The following is a description of a gene set: Human Gene Set: GOBP_REGULATION_OF_MULTICELLULAR_ORGANISMAL_DEVELOPMENT Any process that modulates the frequency, rate or extent of multicellular organismal development. studied in species Homo sapiens, and this is the list of marker genes: CLDN5, TMEM64, HMOX1, ACTN3, COL4A3, TTBK1, LIG4, MAFG, PTGIS, SPAAR (small regulatory polypeptide of amino acid response), TJP1, SAV1, SUV39H1, CD69, ADAM8, MAN2A1, F11R, PHLDA2, SMAD1, SART1, RNH1, RC3H2, AGER, TLE6, PIM1, MIR361, NOG, FBXW8 (F-box and WD repeat domain containing 8), MTMR2 (NCBI Gene Id 8898), BMPR1A, CRB2, CHADL, PITHD1, MIR217, ZNF365, MIR181B1, EFEMP1, APLNR, PTPN11, CSF3, CCBE1, FXR2, FSTL4, THBS1, CTLA4, GPNMB, WNT7A (NCBI Gene Id 7476), ADA, FXR1 (FMR1 autosomal homolog 1), LTF, TNFRSF1A, CCSAP, MT3, IL10, FBXO7, CAMP, DYNLT1, CYP27B1, PTN, MAP1B, BRAF, SS18L1, AKT3, TLR2, IL1RL2, GATA6, APPL2, OAS2, LILRB4, INHBA, PAX2, SFRP1 (NCBI Gene Id 6422), WT1, SPRED3, PLXNB2, NOS3 (nitric oxide synthase 3), H4C16, FANCA, FGF1, BRPF3, LAMA5, NTN1, TGM2, TOX, SPP1, ACACB, MYCN, MIR590, MIR1298, AHI1, TGFB2, LRRC4B, CCN2, NKAP, JAK3, TRAK1, SFRP2, TBX21, HOXA5, CLSTN2, TCTA, IFNL1, MIR137, FZD3, CCL3, MAFF, IL6, YWHAH, AMIGO3, ITGB1, CIB1 (NCBI Gene Id 10519), KLF4, TMEM176A, LEO1, MIR29B1, ASCL1, KAT2A, BTG1, PRMT5, MIR126, SLC9B2, CDK5, MEGF8, GAB1 (GRB2 associated binding protein 1), MYDGF, SLC12A2, FGF13, CX3CL1, OTP, PTEN, DISC1, PLA2G3, TDG, HSPG2, RCOR1, MIR1224, ADM2, NKX6-1, STAT5B, ZBTB1, EP300, RFLNA (refilin A), SOX4, RLN2, FLRT2, SNAI2, TGIF1, FN1, S1PR3, CXCL10, KLF7, GATA4, IL2, CTDSP1 (NCBI Gene Id 58190), ZDHHC21, HCLS1, OSR1, RHOB, SENP1, RNF6, DCC, KIFAP3, HK2, ADM, BRINP1, CTNNA1, RHEX, COL4A2, MIR29C, CUL7, TNFRSF21, XBP1, SIRT6, SLITRK3, IL1A, SHOX2, TP53 (NCBI Gene Id 7157), ITPKA, SMARCD3, ROCK2, SOX17, TNFSF4, PTCH1 (patched 1), BCL11A, MTURN, SIRT2, HES7, CHI3L1, PIK3CG, SERPINE2, ZEB1 (zinc finger E-box binding homeobox 1), RBM15, DCSTAMP, LPIN1, EIF2AK3 (NCBI Gene Id 9451), METTL3, LEF1, NTRK1, KRT84, IGF1, EDN1, MIR106B, TMEM176B, IAPP, PIK3R6, RIPK1 (receptor interacting serine/threonine kinase 1), NCMAP, SHH, CD28, WNT9A, ACIN1, PLCG1, SMO, DBN1 (NCBI Gene Id 1627), TSC22D1, HRG, CDH1, SLC7A5 (NCBI Gene Id 8140), CHODL, OVOL2, NRP1, LINGO4, CDC73, RARB, KRAS, PRL, APCS, FLT1, IL23R, FKBPL, MAPK14, CCL19, B4GALT5, MIR509-1, TSPO, WNT11, OPRM1, MIR505, NKX3-2, ZFPM2, GSX2, ELL3, H4C2, WASF3, HMGB2, BMP2K (NCBI Gene Id 55589), PTHLH, SOX6, SMARCE1, PKP1, SMAD4, IL1RAPL1, IL7R, NIPBL, CYP1B1, ACTL6B, LGALS1, MIR17HG, NRG1, LYN, EFNA5, SEMA6D, SLIT1, SCX, HOXA7, SYT4, PIK3CB, RPS6KA6, GABPA, DLX1, GHSR, KITLG, SLC46A2, MAP2K2, AQP1, RFX3, ARID2, SMAD3, BRPF1, PHOSPHO1, ATP2B4, TPPP (tubulin polymerization promoting protein), NDFIP1, FRZB, TRADD, MIR142 (microRNA 142), SFN, PROC, ZNF354C (NCBI Gene Id 30832), WNK1, IPO7, MIR424, CR1, MCRS1, PLCB1, UFL1, NPR1, ZBED2, ELAPOR2, BCL6, LRG1, ANAPC2, IL27, SPI1, RUFY3, OPTC, WARS2, MIR29A, HELT, INO80, PLXNB3, EPHB2, HSF1, TWIST1, MIR30A, DLL4, NTRK2, PCK1, CTSC, SGPP1, EPHA2, H4C9 (NCBI Gene Id 8294), NOTCH4, MIR222, MITF, TLR3, FOXJ2, CXCR4, NFKBID, PDCD6, MIR34C, THY1, ANKRD54, THPO, STAT1, STAB1, P2RX5, PSEN1, POU4F2, ODAPH, DAG1, HAX1, FERMT1, IL1RAP, RAB21, PPARG, FAM20C, BRD7, TNF, RAG2, TNFSF12, SIGLEC15, HNF4A, MAF, NEDD9, MIR34B (microRNA 34b), ATOH1, PLK2, NKX2-5, GRID2, TRPM4, AGO1, CYBB, NGFR, MIR302A, CST7, MIR30C1, SEMA4D, TRPV2, HOOK3, EHMT1, FOXO4, MIR181A2, EGLN1, IL21, CAPN3, IL12B, SEMA6A, SOX10, MAPT, PROM1, TRIM16, SMAP1, RHEB, CCN4, EEF2K, GDF2, BMAL1, GAL, CLCF1, CERS2, SKI, PARD3, FZD9, EZH2, LAMA2, HDAC1, TMEM100, CASP8, C3AR1, SEMA5A, FSHR, ZEB2 (zinc finger E-box binding homeobox 2), MYB, P4HTM, FOS, FST, LILRB3, BIN1, TFE3, PPP2R3C, PRDM16, BMP6, FADD, PKM, ZBTB16, GATA1, EMP2, MIR503, IL4, CALCA, ARNT, SMARCD2, CTNNB1, ADGRG6, NR2C2, IL6ST, IL2RA, ID2, SEMA3F, TAFA5, ACVR1, SEMA6C, PROK1, HOXB8, AMOT, LIF, SULF1, MME, RXRB, FOXN1, GDF3, ARHGAP4, CXCL13, HLA-DOA, GDI1, DDR2, CTNNBIP1, SASH1, SIX1, GSK3A, TLR9, ANGPTL4, PRMT6, NFAM1, EXTL3, FIG4, EPN1, CD2, FAM210B, IFITM5, PRDM1, SLITRK1, ASCL2 (achaete-scute family bHLH transcription factor 2), STAT3, HES5, AXL, PRKCZ, TOB2, G6PD, ERFE, HHEX, WNT6 (Wnt family member 6, NCBI Gene Id 7475), MYOZ1, TESC, UCHL5, GDF6 (growth differentiation factor 6), PTPRZ1, SMARCA2, H4C11, PURB, ZAP70, ZNF219, MIR181C, RYK, RTN4R, DRD3 (NCBI Gene Id 2111), SOX15, CD160, MIR34A, CYLD (CYLD lysine 63 deubiquitinase), PLXNA3, PML, MIR329-1, ROBO2, TBX2, SMOC2, ADRB2, LIMK1, PRKD2, MIR138-1, FOXC1, FBXW7, NKX6-3, NR2E1, SPINK5, NEURL1, ATF4, MYC, BMPR2, MIR873, INSR, ZMPSTE24, ERAP1, AP3D1, LCK, JMJD8, CMA1, CUL4A, JUNB, MAP6, KRT36, TP73, CD24, KIAA0319, S1PR2, FOXC2, FOXJ1, ATXN1, TADA3, BRD1, MIR221, NFKBIA, RIPK2, MIR495, DLL1, TIAM1, RARA, SMPD3, RGS14, RACGAP1, IFNG, NR5A2, WDPCP, STARD13, RHOJ, DNAJB11, FERD3L, ERRFI1, MMP9, VGLL4, SPHK1, CCR1, JAM2, GPR137, RHOA, OSR2, IST1, ULK1, NLGN2, NBR1, SPINT1, EFNA3, IL4I1, UBASH3B, ANXA3, CTSK, SPRED2, GATA2, LTA, GRM5, ADGRB1, ISLR2, IDH2, SPRY2, VEZF1, RGS2, PLXNB1, TNFAIP6, DLX2, EMILIN1, SKIL, SLITRK2, SYK, APELA, SOS1, FUT1, LAMA4 (NCBI Gene Id 3910), TBX20, E2F1, ISG15, BAD, CHD7, MTOR, LRRTM3, TBC1D24, PHF10, H4C5, DLL3, ZNF304, IL17D, MIR143, MIR208A, TRAF6, LRRC24, LRTM2, CD40, MIR451A, RPTOR, GLI1, IL1B, NPTN, TFAP2A, WNT2B, CREB1, WNT1, YEATS2, PTK2B, CTR9, SOX9, SOX11, TNFSF9, JAK1, TWF2, NFRKB, HEYL, DSPP, RECK, PIK3R1, IL18, MIR17, CLEC4G, TENM4, BMP2, NKX6-2, FLRT1, HPSE, RBPJ, NOTCH1, CDKN1B, ADAMTS7 (ADAM metallopeptidase with thrombospondin type 1 motif 7), LRRN1, ANGPTL3, ZC3H8, ADCY10, FSTL3, MIR101-1, ZBED3, MIR518B, HLA-B, PTPRM, INO80B, RAMP2 (NCBI Gene Id 10266), SULT2B1, YTHDF2, KL, GJD4, IKZF3, BHLHE40, IFNA2, CLEC12A (NCBI Gene Id 160364), MED1, CRTAM, GBX1, CELA1, EMC10, CDH3, HEY1, RNF112, ACVR2A (activin A receptor type 2A), CD36, WWTR1, IL15, TXLNG, JUP, DSCAM, XRCC5, NKX2-2, ENAM, DDRGK1, RGCC (NCBI Gene Id 730127), MIR1-1, LPAR3, PNP, VSIR, F3, IL4R, ANXA2, DICER1, HSPA9, RELN, PITX3, SMARCB1, MIR31, DR1, OR10J5, PRDX2, PRUNE1, MIR210, CD27, MIR223, MYH6, WNT4, DAAM2, GADD45A, KDR, PPP1R16B, ATP2B1, FEZF2, RNF41, H4C12, SYNJ2BP, CDKN2A, ADIPOQ, SHANK3, HSPB1, MAP3K13, VSX2, TRPS1, CCND1, BCOR, PAFAH1B1, PRKCB, DCN, ACTB, DKK4, CXCL8, KDF1, ZBTB7B, PPP1R12A, LILRB1, HLA-DRA, AGGF1, AMELX, MEIS2, CAPRIN2, MIR21, PAX6, AGRN, CNOT4, APOH, NIN, ERBB2, DKK1, ANGPT4, ARID1B, IQSEC2, TMEM119, MIR375, IL5, ASPN, SORL1, PRKCI, SLC30A1, ECM1, SPRY1, HSPA1B, CLPTM1, KCTD11, SMAD7, RARG, SLITRK4 (NCBI Gene Id 139065), STAT5A (signal transducer and activator of transcription 5A), PRKG2, PPARD, HES3, MYRF, YJEFN3, DDAH1, THBS4, TOMM70, ADGRV1, CCNB1, VNN1, ETS1, HMGA2, STAU2, GATA3, ANGPTL7, ESRP1, TSPAN18, ACVR1B, YAP1, ZFYVE27, PAK1, FGFR1, MCF2, ADAMTS1, TGFBR2, MIR125A, C1QC, MIR30E, AKAP6, RNF10, TIE1, KAT5, MIR19A, P2RX7, CBFB, ROBO1 (roundabout guidance receptor 1), MIR200B, H4C1, PRKCA, NCOA3 (NCBI Gene Id 8202), TP63, AKT1, ARID1A, CXCL12, E2F2, PRLR, TEK, TLR4, ADAM10, HLA-DRB1, EIF6, EPHA1, PGLYRP3, SPRED1, HSPA1A, QKI, ERBB4, EPHB1, DPYSL5, HIPK2, DIP2B, ITGB2, KAT6A, C3, PGLYRP1, TRPC5, RGS4, RUNX3, HES6, SEPTIN7, CAPRIN1, BAIAP2, S100A10, WARS1, GPR37L1, GPR4, MIR185, ADGRA2, KRT17, POGLUT1 (NCBI Gene Id 56983), KLF13, ARMCX5-GPRASP2, SLAMF8, SHTN1, TBX5, PRKCH, ZNF683, CEBPA, GTF2I, RASSF2, ZFP36L2, MIR18A, AMIGO1, TPBG, ULK2, LEP, ST8SIA2, LRRN3, IL7, PCID2, PRTG, FGL2, NUPR1, LINGO2, ASPM, WDR5, SPART, MESP1 (mesoderm posterior bHLH transcription factor 1), TGIF2, LGALS9, FASLG, SFRP4, S1PR1, CBLN1, DUSP10, FOXP3, MIR23A, TNFSF11, PDE3B, VAX1 (NCBI Gene Id 196056), MAP2K1, SLIT2, MGP, IFRD1, HLTF, SOCS1, CREB3L1, HES2, MIR150, GDNF, MIR640, GDF5, GPER1, BRCA1, NUMB, GPM6B, NOCT, JAG1, TRIM11, CDH5, NSUN5, MIR193A, BMPR1B, VSTM5, WNT3, TAPT1, NAP1L1, VASH2, MPL, HES1, ZNF675, BTN2A2, BMP4, RFLNB, DOCK7, SERPINE1, LOXL3, TRAK2, FGF10, ISL1, INO80D (INO80 complex subunit D), PPP3CA, CUX2, MIR548C, VCL, ITGA5, MIR377, FAXDC2, HYAL1, HOXA9, LNPK, NUMA1 (nuclear mitotic apparatus protein 1), SGF29, TCIM, SPRR5, IL15RA, MECP2, MACF1, DMRTA2, IL12RB1, HIF1A, PROX1 (NCBI Gene Id 5629), SYNDIG1, HEY2, MDK, BMP7, GLUL, TRIB1, RND2, SHC1, CXCR3, ANXA1 (NCBI Gene Id 301), FBXO5, SOX5, ABL1, NUMBL, SOD1, SKIC8, SOCS5, PTPN13, ADAMTS9, RC3H1 (NCBI Gene Id 149041), ANKH, TNMD, GPRASP3, EPHA4, JARID2, PPARGC1B, MIR1908, IL13, IL17A, SEMA3G, IL36B, BATF, MMP14 (NCBI Gene Id 4323), CD74, MIR27B, KAT2B, OPA1, MEAF6, IRF7, PBRM1, SH3RF1, MSX1, RASGRP1, REG3A, ADGRB3, ABCA12, AXIN2, ADAM12, MYSM1, GHRL, ABCB10, FCRL3, CD34, LAMA1, MIR10A, NRARP, CCR2, PAX8, MIR132, FANCD2, TADA2A, GRN, SERPINF1, ECSCR, GPR171, BRD4, HOXA11, STK25, BAG6, LOX, ADGRB2, PTPRS, MIR885, FGF16 (NCBI Gene Id 8823), AMBRA1, FGFR2, XDH, STIM1, WNT2, HOPX, IRF4, KAT7, NRXN1, CFTR, MIR15A, TMEM178A, TMEM98, TGFBR3, MIR486-1, GBX2, KDM1A, GPR65, GFAP, MYOD1, PTPN6, SMARCA4, KAT14, GLG1, CAV3, SP1, MIR130A, ZFP36L1, MIR212, DUSP6, PKP3, CDON, CCN6, SOS2, SLC8A1, NFE2L1, FMR1, MAFB, IHH, AP3B1, MIR18B, SEMA4F, FGF20, ENG (endoglin), CTDP1, KLF10, ZMIZ1, CLCN2, DLG5, TNFAIP3, ZFP36, MIR19B1, AJAP1, CCM2, RB1, TREM2, ADAMTS12, TNR, PF4, NOS1, STK11, MATN1, RETN, MIR199B, NPPB, CYP26B1, PTPN2, SMARCC2, WDR62, KLHL25, BDNF, LAG3, OTX2, SRF, MBOAT2, PTCH2, CTNND1, SIRT1, KEAP1, MIR99B, MIR205, FZD4, TERT, EGR2, TBX3, TM4SF19, TNFRSF1B, SOX13 (SRY-box transcription factor 13), H4C4, L3MBTL1, OXT, FGF2, SEMA3E, CARD11, DSG2, MUSTN1, SGMS2 (sphingomyelin synthase 2), PPARA, PARP2, NFATC4, SMARCD1, ADD1, ITGB3, ACTR8, KIF14, SRRT, DRAXIN, MYCL (MYCL proto-oncogene, bHLH transcription factor), OCSTAMP, TENT5A, S100B, KIT (NCBI Gene Id 5086), LILRB2, EFNB3, HAP1, MBIP, MIR25, LRRC17, FEZF1 (NCBI Gene Id 392779), CD109, TFPT, MMP20, FYN (FYN proto-oncogene, Src family tyrosine kinase), SMARCC1, POU4F1, MIR125B1, NELL1, VASH1, MAPK7, NLRP5, AMIGO2, EPN2, NFE2L2, SNW1, NR5A1, CAV1, DHX36, PSG9, INPP5D, NRDC, RXRA, VEGFA, LGALS3, H4C3, H4C6, CDK6, LHX2, CHRNA7, CLIC3, KLF2, KCNK18, SARS1, BTG2, AMTN, MIR204, TRIP12, HTN1, H4C8, PDPK1, CD83, TNFRSF11A, UTP25, BGLAP, PDCL3, ZC3H12A, SLITRK5, SIX4, RUNX2, COMP, BHLHE41, ACVR2B, IL20, FSHB, RAPGEF2, PKDCC, SRGN, RAG1, ABCC8, TNFSF18, KHDC3L (NCBI Gene Id 154288), ID4, HLA-G, TSPAN12, TIAM2, VEGFB, ANGPT2, H4C15, ZNF16 (NCBI Gene Id 7564), KRT1, ACVRL1, ALOX15B, NOTUM, GLI3, DLG1 (discs large MAGUK scaffold protein 1), TNFRSF11B, TBXA2R, WNT10B, MIR492, MIR20A, EEIG1, RUNX1, PLAAT4 (phospholipase A and acyltransferase 4), CDH4, GDF9, CD80, FBN1, SP100, RAB14, NLRP3, ITGAX, CEMIP2, MIR494, MIR30B, ATF2, FCGR2B, NF2, NAXE, IRF1, MIR199A1, ZZZ3, BMPER, RAPGEF3, GORASP1, FES, ZNF335, IKBKB, PLXND1, LTBP3, TNN (tenascin N), REST, TNFRSF12A, TGFBR1, ETV5, CDK18, OBSL1, HLX, LAMA3, CD4, PLAG1 (PLAG1 zinc finger), MSX2, ALOX5, SRSF6, DTX1, SRPX2, YPEL4, MAP2 (microtubule associated protein 2), CLSTN1 (calsyntenin 1), NR1D1, ADNP, RACK1, CARTPT, EMILIN2, LRP2, PI16 (peptidase inhibitor 16), BMP10, GLI2, EPHB3, ASIC2, LRP8, CCL24, ISM1, ATOH8, MIR200C, CSF3R, LIN28A, ANKRD27, GPR68, MIR20B, CAMK2B (NCBI Gene Id 816), IL17F, PRELID1, FBLN5, MTDH, CCR3, LOXL2, ZNF488, LDB1, PPP1CC, MACROH2A2, TAL1 (TAL bHLH transcription factor 1, erythroid differentiation factor), JCAD, SOX12, INHA, CDKN1C, BMP1 (NCBI Gene Id 649), DMP1, PLXNC1, PCM1, PGLYRP2, PRKX, SYNGAP1, PDCD10, EPHA7, KAT6B, FOXG1, CDKL5, CD46, RASSF10, TESPA1, PARP6, CD86, RAB7B, MIRLET7G, CUX1, F2, POR, SEMA7A, FGF23, RHOH, SLC4A2, SASH3, MIR146A, CFL1, ETV2, CSF1, SLITRK6, ACTL6A, FGF9, MIR145, NCKAP1L, SCIN, INO80E, MAPK11, TRPC6, IL2RG, PTPRD, CLDN18, VEGFC, ENPP1, FOXA2, NLGN3, BRD2, FOXO3, BLTP1, ZBTB46, TCF7 (transcription factor 7), H4C14, CAMK4, COL14A1, RELA, TRIM32, CCN1, PTPRC, FGF18, RRAS (RAS related), LDLR, FBN2, PRXL2A, NEFL, SPEN, KRIT1, WNT5A, XRCC6, HOXB3, ID1, MINAR1, MIR487B, TAOK3, PIK3CD, TRIM46, TYMP, CNMD, ING5, KCNK2, RBM19, YY1, GPR137B, GFI1B, PAK4, ITGB8 (integrin subunit beta 8), MIR939, GAS6, FOXE3, TMEM131L, MALT1, GPR55, HESX1, GOLGA4, LRP4, PAF1, ROCK1, DCT, TMIGD2, ANO6, HMGB1, TG, BASP1, IFNB1, PRKD1, XRCC2, RGMA, CX3CR1, DRD2, B2M, HGS, ACTR5, GRHL1, L1CAM, CD101, RTN4, SHB, HSPB6, DROSHA, ZFPM1, PIAS3, TYROBP, HDAC6, RUVBL2, C5AR1, NLGN1, WNT9B, PER2, CDK1, SPARC, H4C13, CLSTN3 (calsyntenin 3), MMRN2, ITPKB, CBLN2, HMGB3, IL34, CRABP2, PRMT1, LGI4 (leucine rich repeat LGI family member 4), EGF, METRN, CEBPB, MIR378A, WNT3A, IL23A, REG3G, MIR15B, LRRTM1, S100A1, DAB2IP, MEIS1, EVI2B, HDAC2, THBS2, NF1, AGO2, CCL11 (C-C motif chemokine ligand 11), CDKL3, MAG, SIX2, PTH, MIRLET7B, DAB1, ETV4, ATRAID, RBP4, GREM1, NINJ1, NTRK3, FLRT3, EGR3, MEF2C, EFNA1, RUVBL1, LHX1, ZPR1, TLX2, AQP3, SOX8, STATH, AHSG, INO80C, MIR24-1, MACROH2A1, SLC20A2, VDR, CEACAM1, BTK (Bruton tyrosine kinase), MIR16-1 (microRNA 16-1), SMURF1 (NCBI Gene Id 730332), APOLD1, NME2, PGK1, MIR214, KLK3, HIPK1 (homeodomain interacting protein kinase 1), NODAL, NGF (NCBI Gene Id 4803), MIR92A1, FOXP1, TGFB1, SEMA4A, NFKBIZ (NCBI Gene Id 64332), OLIG2, NOTCH2, PRKDC, GGCX, LRRTM2